The following is a description of a gene set: Abnormal vagina morphology species: Homo sapiens Human Gene Set: HP_ABNORMAL_VAGINA_MORPHOLOGY Any structural abnormality of the vagina., and this is the list of marker genes: UBR1, GATA3, ZMYM2, IL17RA, TP63, RSPO2, CCNQ, FGFR2, SCLT1, DACT1, COL3A1, CEP290, KIF7, BBS12, NR2F2, ZEB2, PPP1R12A, NPHP1 (nephrocystin 1), DYNC2I2, DHX37, RNU12, B3GLCT, NR0B1, BUB1B, NR5A1, POLR1B, CEP19, PAX3, WWOX, DYNC2LI1, SALL4 (NCBI Gene Id 57167), CYP11B1, IFT74, VAMP7, IL17F, RIPK4 (NCBI Gene Id 54101), BBS4, POLR1D, BUB1, RECQL4 (NCBI Gene Id 9401), DHCR7, BUB3, RELA, STAT6 (signal transducer and activator of transcription 6), MKS1, IFT172, JAK3, ARL6, MNX1, SMAD3, PI4KA, SRY, ITGA8, SCAPER, BBS5, POR, ITPR1, CCDC28B, CYP17A1, MTM1, IL17RC, TRIM32, CYB5A, BCOR, TBX4, SDCCAG8 (NCBI Gene Id 10806), BBS1, SRD5A2, GLI3, CYP11A1, DHH, WT1, MAMLD1, FRAS1, COL7A1, KIF14, GATA4, IFT80, IFT27, BBS7, TTC8, NAB2, ARHGAP31, TBX3, FH (fumarate hydratase), HOXA13, WDPCP, BBS10, HYLS1, TCOF1, CLEC7A, DYNC2H1, DDB1, TRIP13, INTU, BBIP1, TRAF3IP2 (TRAF3 interacting protein 2), WNT4, MAP3K1, COL4A6, BBS2, MKKS, POLR1C, SPINT2, PPP2R1A, LZTFL1, BBS9, CAPN15, CEP57, FREM1, SLC35A2, SOX9, WNT3, GRIP1, IRF6, AR (NCBI Gene Id 367), TCTN3, CFAP418, PAX6, SALL1, LONP1, COL4A5, ZFPM2, IL10RB, WDR35, EFEMP1, CHRM3, FREM2, DYNC2I1